The following is a description of a gene set: Any process which produces inosine monophosphate from derivatives of it, without de novo synthesis. species: Homo sapiens Human Gene Set: GOBP_IMP_SALVAGE, and this is the list of marker genes: APRT, AMPD3, AMPD2, AMPD1, HPRT1